Given this list of marker genes AQP9, SLC14A2, AQP7, SLC14A1, AQP7B, AQP3, AQP10, AQP8, here is a description of the gene set: Human Gene Set: GOMF_UREA_TRANSMEMBRANE_TRANSPORTER_ACTIVITY Enables the transfer of urea from one side of a membrane to the other. Urea is the water soluble compound H2N-CO-NH2. species: Homo sapiens